Given this list of marker genes S100b, App, Ager, Capza2, Hmgb1 (NCBI Gene Id 15289), here is a description of the gene set: Advanced glycosylation endproduct receptor signaling Mouse Gene Set: REACTOME_ADVANCED_GLYCOSYLATION_ENDPRODUCT_RECEPTOR_SIGNALING species: Mus musculus